The following is a description of a gene set: Mouse Gene Set: REACTOME_CELL_DEATH_SIGNALLING_VIA_NRAGE_NRIF_AND_NADE species: Mus musculus Cell death signalling via NRAGE, NRIF and NADE, and this is the list of marker genes: Akap13, Arhgef11, Rasgrf2, Ngfr, Obscn, Sqstm1, Arhgef5, Trio, Fgd1, Prex1, Casp3, Uba52, Bad, Uba52rt, Arhgef10l, Rps27a, Itgb3bp, Sos2, Arhgef10, Abr (NCBI Gene Id 11357), Itsn1, Arhgef17, Aph1a, Arhgef39, Arhgef38, Arhgef15, Bex3, Arhgef2, Arhgef33, Mapk8, Plekhg2, Vav3, Arhgef12, Plekhg5, Fgd2, Arhgef1, Arhgef6, Rac1, Psenen, Kalrn, Vav1, Psen1, Traf6, Tiam2, Ywhae, Ect2, Arhgef18, Arhgef9, Arhgef3, Mcf2, Arhgef26 (Rho guanine nucleotide exchange factor 26), Ngef, Ncstn, Fgd3, Bcl2l11, Arhgef19, Arhgef25, Aph1b (NCBI Gene Id 69695), Ngf, Arhgef7, Ubb, Ubc, Casp2, Arhgef16, Vav2, Gna13, Mcf2l, Arhgef37, Sos1 (SOS Ras/Rac guanine nucleotide exchange factor 1), Fgd4, Net1